The following is a description of a gene set: Mouse Gene Set: REACTOME_APOPTOTIC_CLEAVAGE_OF_CELL_ADHESION_PROTEINS studied in species Mus musculus Apoptotic cleavage of cell adhesion proteins, and this is the list of marker genes: Pkp1, Dsg3, Ctnnb1, Tjp2, Casp3, Tjp1, Dsg1a, Ocln, Dsp, Dsg2